The following is a description of a gene set: Genes predicted to be targets of miRBase v22 microRNA mmu_miR_130a_3p, mmu_miR_721 in miRDB v6.0 with MirTarget v4 prediction scores > 80 (high confidence targets). from publication Chen Y, Wang X (PMID 31504780) Mouse Gene Set: MIR_130A_3P_MIR_721 studied in species Mus musculus, and this is the list of marker genes: Sulf1, Plcb1, Hoxb1, Cnot7 (CCR4-NOT transcription complex, subunit 7), Cnot6, G3bp2 (NCBI Gene Id 319444), Wnk1, Btaf1, Mllt6, Slmap, Wdfy3, Sowahb, Mat2b, Med15, Mctp1, Gpatch8, Eogt, Smarcd2, Snip1, Zfp609, Acsl4, Mon2 (MON2 homolog, regulator of endosome to Golgi trafficking), Vps29, Nacc2, Acsl1 (NCBI Gene Id 56355), Pparg, E2f2, Il25, Socs5, Relch (NCBI Gene Id 75582), Heg1, Lonrf1, Sh3d19 (SH3 domain protein D19), Cbfb, Tbc1d8, Mid1ip1, Dpysl2, Sphk2, Usp32, Rap2c, Rfx7, St6galnac3, Csnk1g1, Klhl20, Dennd1a, Btbd3, Pmepa1, Mex3d (mex3 RNA binding family member D), Impdh1, Mfsd6, Arap2, Smap1, Sbno1, Nectin3, R3hdm1, Atg16l1, Tnf, Eda, Ankib1, Ptprg, Rab5a, Gja1, Pdgfra, Fastk, Kcna4, Adcy1, Ppp6r1, Pgm2l1, Tspyl2, Prkd3, Emx2, Hprt1, Cpeb1, Tsc1, Dennd10, Zfp655, Robo2, Ptp4a1, Ago4, Kcnj2, Kdm2a, Kmt2c, Cfl2, Cyld, Dll1, Zfp11, Btf3l4, St18, Map3k12, Psap, Gga3, Arhgap12, Ube2d2a, Erbin, Acbd5, Phf3, Mdfic (NCBI Gene Id 16543), Fut9, Rasd1, Btbd7, Ston2, Togaram1, Tbl1xr1, Zbtb4, Jarid2 (NCBI Gene Id 97879), Calm2, Chst1, Lgalsl, Mmgt1, Pxk, Appl1, Mdm4, Ccdc126, Esr1, Pou4f1, Rnf38, Tbc1d12, Mecp2, Ubl3, Sel1l3, Nol4, Plekhg5, Mapk8, Cast, Kbtbd8, Fermt2, Caprin2, Vps37a, Miga2, Tapt1, Pcnx1 (NCBI Gene Id 80635), Rtn1 (reticulon 1), Garem1, Lcorl, Spred1, Lrrtm2, Enpp5, Tes, Gpr137c, Wnt2b, Psd, Zmat3, Pak6, Dgke, Ulk2, Ccny, Larp4, Btg1, Jmy, Mapk1, Acvr1, Cdk19, Usp8, Med12l, Dnajc24 (DnaJ heat shock protein family (Hsp40) member C24), Abhd3, Lrp8, Smoc1, Ago1 (argonaute RISC catalytic subunit 1), Dsel, Hs3st5, Wee1, Naa30, Lonrf3, Snx5, Ar, Zcchc14, Skida1, Laptm4a, Mybl1, Cmpk1, Dcbld2, Stx6, Atp2b2, Fibin, Daam1, Lrig1, Cds1, Mdn1, Nckap5, Fmr1, Snapin, Snx2, Akap11, Akirin2 (NCBI Gene Id 67185), Lrp4, Mbnl1, Prkaa1, Fcho2, St8sia5, Arhgap1, Fam234a, Zfp113, Reps2, Maf, Tgfbr1, Bnip2, Blcap, Tet3, Nsd3, Phaf1, Cd69 (NCBI Gene Id 76049), Cltc, Iqgap2, Csmd1 (CUB and Sushi multiple domains 1), Spire1, Socs6, Npepl1, Casd1, Ldaf1, Sybu, Clcn5, Jade1, Mb21d2, Stxbp5, Smoc2 (SPARC related modular calcium binding 2), Stimate, Atxn1, Arhgap21, Ldlrad4, Adamts20, Mphosph9, Brwd1, Spart, Itpr1, Stim2, Pik3cb, Map3k8, Cep170, Sgcb, Tbcel, Memo1, Smad5, Zbtb18, Abcc5, Tmem250, Acer2, Rnf216, Elk3, Ereg, Psd3, Phf12, Prr14l, Clip1, Epc2 (enhancer of polycomb homolog 2), Neurog1 (NCBI Gene Id 18014), Gng12, Gon4l, Tshz1, Tnrc6a, Tnrc6c, Ddx6, Thsd7a